The following is a description of a gene set: The gamma-glutamyl cycle is a six-enzyme cycle that represents the primary pathway for glutathione synthesis and degradation. One step is the cleavage of 5-oxo-L-proline (OPRO) to form L-glutamate, coupled to the hydrolysis of ATP. This is catalysed by 5-oxoprolinase (OPLAH) is a homodimeric, cytosolic protein. Defects in OPLAH can cause 5-oxoprolinase deficiency (OPLAHD; MIM:260005), an extremely rare disorder of the gamma-glutamyl cycle about which debate continues as to whether it is a disorder or just a biochemical condition with no adverse clinical effects apart from 5-oxoprolinuria. studied in species Homo sapiens part of: Metabolic disorders of biological oxidation enzymes Reactome Pathway: Defective OPLAH causes OPLAHD, and this is the list of marker genes: OPLAH